The following is a description of a gene set: Human Gene Set: GOMF_LIPOTEICHOIC_ACID_BINDING Binding to lipoteichoic acid. studied in species Homo sapiens, and this is the list of marker genes: CD14, TREM2, DMBT1, CD6, NLRP6, LBP